Given this list of marker genes AACS, ACSS3, SLC27A5, HMGCLL1, HMGCL, HMGCS2, here is a description of the gene set: The chemical reactions and pathways resulting in the formation of ketone bodies, any one of the three substances: acetoacetate, D-3-hydroxybutyrate (beta-hydroxybutyrate) or acetone. Biosynthesis involves the formation of hydroxymethylglutaryl-CoA, which is cleaved to acetate and acetyl-CoA. Human Gene Set: GOBP_KETONE_BODY_BIOSYNTHETIC_PROCESS species: Homo sapiens